The following is a description of a gene set: Any process that modulates the frequency, rate or extent of a process involved in the formation, arrangement of constituent parts, or disassembly of a mitochondrion. Human Gene Set: GOBP_REGULATION_OF_MITOCHONDRION_ORGANIZATION studied in species Homo sapiens, and this is the list of marker genes: MOAP1 (modulator of apoptosis 1), PRKN, YME1L1, FIS1, IER3, PLSCR3, HDAC6, RHOT1, GOLPH3, ADCK1, VAT1, GHITM, ZDHHC6, MCU, PID1, SLC25A31, FAM162A, DDHD2, BAX, MIEF1, KDR, GPX1, HUWE1, DDHD1, STAT2, PLD6, PRELID1, SQSTM1, INF2, RALBP1, BBC3, GCLC, NOL3, PPIF, SIVA1, SSBP1, SLC30A9, PARL, PPARG, MGARP, MICU1, BOK, GSK3A (glycogen synthase kinase 3 alpha), SLC25A4, FZD9, PDE2A, LMNA, FXN, TNFSF10, TP53, CYRIB, PRMT6, BMF, SIRT7, RAP1GDS1, MAPT, HIP1R, DNM1L, LRRK2, MLLT11, MYO19, MARCHF5, MFF, IGF1, BCL2L1, C11orf65, GPER1, EP300, RALA, VPS35, MSTO1, AKT1, BAD, SLC25A6, DCN, PISD, MTCH2, TRIAP1, PINK1, OMA1, HGF, IFI6, ENDOG, CLU, ATP13A2, PGAM5, MMP9, PMAIP1, SPIRE1, PSMD10, AURKA, BCL2L11, TMEM14A, STOX1, HIGD1A, IRGM, BNIP3, ACAA2, HRK, MPV17L, BAK1, CHCHD10, OPA1, BID, PYCARD, SLC25A5, ZNF205, PLAUR, TMEM102, HSPA1A, ATP5IF1, MUL1, MIEF2, SLC35F6, TMEM135, GSK3B, TFRC, BIK